The following is a description of a gene set: Human Gene Set: SMID_BREAST_CANCER_BASAL_DN We explored whether the five previously reported molecular subtypes in breast cancer show a preference for organ-specific relapse and searched for molecular pathways involved. The intrinsic gene list describing the subtypes was used to classify 344 primary breast tumors of lymph node-negative patients. Fisher exact tests were used to determine the association between a tumor subtype and a particular site of distant relapse in these patients who only received local treatment. Modulated genes and pathways were identified in the various groups using Significance Analysis of Microarrays and Global Testing. Bone relapse patients were most abundant in the luminal subtypes but were found less than expected in the basal subtype. The reverse was true for lung and brain relapse patients with the remark that absence of lung relapse was luminal A specific. Finally, a pleura relapse, although rare, was found almost exclusively in both luminal subtypes. Many differentially expressed genes were identified, of which several were in common in a subtype and the site to which the subtype preferentially relapsed. WNT signaling was up-regulated in the basal subtype and in brain-specific relapse, and down-modulated in the luminal B subtype and in bone-specific relapse. Focal adhesion was found up-regulated in the luminal A subtype but down-regulated in lung relapse. The five major molecular subtypes in breast cancer are evidently different with regard to their ability to metastasize to distant organ(s), and share biological features and pathways with their preferred distant metastatic site. Genes down-regulated in basal subtype of breast cancer samles. studied in species Homo sapiens from publication Smid M, Wang Y, Zhang Y, Sieuwerts AM, Yu J, Klijn JG, Foekens JA, Martens JW (PMID 18451135), and this is the list of marker genes: DZIP3, LINC01949, HPGD (15-hydroxyprostaglandin dehydrogenase), F13A1 (NCBI Gene Id 2162), ENTPD3, CPD, IKBKB, GP2, COG7, SOCS2 (suppressor of cytokine signaling 2), ANG, FBXL7, SPTLC2, NAIP, STARD3, BATF, FABP4, FGFR3, NF1, CEACAM6, INPP4B, ANO1, RBM47, MLPH, MAK, HEMK1, NTRK2, HGD, TIMP4, TNXA, ACADSB, CAMK2B, REEP5 (receptor accessory protein 5), SLC4A8, ABCC8, COMP, GNG13, ZNF552, BEX1, ANOS1, MAST4, GRIA2, AGR2, TSPAN13, SIX1 (SIX homeobox 1), AAMDC, ELAPOR1, CYP2B6 (NCBI Gene Id 82059), CACNA1H, EVL, SYT17, TFAP2B, ALCAM, MCF2L, LRRN3, KCTD3 (potassium channel tetramerization domain containing 3), ESR1, DGKD, TRAK1, STK39, IRX5, MSX2, ZNF43, PIDD1, LRBA, TOB1, HPX, ALG12, BCAS4, TTC9, CACNA2D2, ADCY9, TMEM143, SLC24A1, ABCA12, CACNG4, SORL1, HSDL2, OGN, C4A, SVEP1, TRIL, GTF2H2C, GJA1, OLFML3, FASN, SNHG14, NOVA1, FCMR, UBA7, TRAF5, TBC1D9, TRIM68, WWOX (WW domain containing oxidoreductase), PIERCE1, DEPTOR, ADIRF, BLVRB, MED24, FMO5, ATRNL1, TSPAN8, IL33, CYB5A, GGT1 (NCBI Gene Id 91347), CX3CR1, MED13L, RPS20P22, PDCD4, BLVRA, ZMYND8, RASSF1, NR4A2, CLSTN2, PDGFD, KCNE4, CXCL14, SMPD3, CFB, ITM2A, AOX1, HEBP1, XRCC4 (NCBI Gene Id 7518), SLC1A1, FAIM2, CYP2A6, SCNN1A, SLC39A6, SCCPDH, DNAAF1, GRP, SLC48A1, KRT8, KAZALD1, NAV3, AGL, ABCB1, ACACB (acetyl-CoA carboxylase beta), HGF, CA12, THBS4, BIK, ADIPOQ (adiponectin, C1Q and collagen domain containing), ATP8A2, LINC01503, TMEM101, REEP1, CEACAM5, CHAD, DCN, PAMR1, KRT18, CCNO (NCBI Gene Id 9998), C1QTNF3, MREG, TPSAB1, TUBA3E, BMI1, KIF13B, MAP3K12, NADSYN1 (NCBI Gene Id 55191), SLC9A1, CREB3L1, CDK12, RHBDL1, NPDC1, PLEKHF2, COL4A5, IFT122, TCEAL4, PNPLA2, SLC2A8, GPC1-AS1, RND1, EVA1B, SLC26A3, NHERF1, SNX1, PCSK6, LONP2, TRGC1, MYT1, ADCY1, ASPH (aspartate beta-hydroxylase), DHCR24, CILP, CACNA2D3, SERPINA5, ZBTB18, ATP1A2, ADRA2A, FLRT3, TFPI2, CHN2, CFAP69, CLBA1, EPOR (NCBI Gene Id 2057), C14orf132, ASPA, BRINP2, MFAP5, MAPT, SSTR2, PGR, IL6ST, ALOX15B, ARL3, RET, PSD3, PLXNB1, SPDEF, MAN1C1, C3orf52 (NCBI Gene Id 79669), PTPRT, CEP15, EPHX2, GSE1, SERHL, CYP4F8, NKAIN1, ABCA3, CAMK2N1, ENPP1, HMGCS2, CCDC170, PLIN1, PCK1, DNAI7, RAB17, PAX2, SYTL2 (NCBI Gene Id 84564), HSPB8, AR, GPRC5A, CRY2, SCD, DNALI1, DCAF10, ITGBL1, BCAS1, DUSP4, KCNAB1, GSTM3, CASD1, SCGN, PTPRN2, BMERB1, SLC1A4, RAPGEF3, RBP4, SLC16A6, FAM131B, PBX1, NAT2, ECM1, AKR7A3, RNASE4, OMD, ZNF446, EFHC1, HBA1, ITGA7 (NCBI Gene Id 81988), TTC12, PLAT, PLA1A, MACIR, LAMP5, SYBU, HOXB2, PLAAT4, CSAD, GLRB, SLIT3, GNMT, BBS4, RARA, LRRC17, CITED1, RTN1, KAT6B, VIPR1, AMDHD2, JMJD7-PLA2G4B, PRKACB, TTC39A, IQGAP2, IRS1, UGT2B15, LEP, CLCA2, PATJ, CYBRD1, NBEA, UGT2B11, RBM19, PTP4A2, RABEP1, SPAG16, KIF16B, SLC18A2, ACSM5, MYH11, HSPB1, CCN5, BRINP3, TCN1, SEPTIN8, UBL3, SCUBE2, PNPLA4 (patatin like phospholipase domain containing 4), CELSR1, BCL2, CAPN9, PLA2G10 (phospholipase A2 group X), SEC14L2, MZF1, LRIG1, LIAS, SPARCL1, CDS1, CLDN5, BTG2, SEMA3C, ICA1, C2CD2L, SPATA7 (NCBI Gene Id 55812, spermatogenesis associated 7), HIGD1B, ZNF329, NUCB2 (nucleobindin 2), PDZK1, RHOH, CCNG2, HCFC1R1, FOSB, NEBL, DDO, LIPE, TJP3, CFAP45 (NCBI Gene Id 25790), ELOVL2, GJA4, EFCAB2, NPY1R, TSPAN1, GSTT2, SELENOP (selenoprotein P), HOXB6, MAGED2, CXXC4, CST5, INPP5J, SNED1, GNA14, LDLRAD4, CACNA1D, ERBB4, CATSPERB, PPDPF, CRISP3, COL4A6, TRIM3, MS4A2, EEF1A2, STS, SLC38A1, ABCA8, MDM1, ERBB3, PGGHG, PPIP5K1, NAT1, NCOA3, ACSL3, ANXA9, TK2, CPB1, PGAP3, WWP1, TSKU, FUT8, RAPGEFL1, FAAH, ARMT1, TPPP3, FCER1A, ALG8, KCND3, EMCN, CLEC3B, HSPA2, STC2, APPBP2, DLG5, ZNF385D, SCGB1D2, DIO1, CFD, PRLR, DNAJC1, TNNT1, IFT140, CAMP, TM7SF2, HNMT, UCP2, ALDH3B2, PCDHA9, CERS6, ATP8A1, STK32B, POLM, MYB, MTARC1, RGS11, GALNT6, ZNF652, G6PC3 (NCBI Gene Id 92579), NEDD4L, ARHGAP32, PLCL1, AMIGO2, ACKR3, PCLO, RETREG1 (reticulophagy regulator 1), SSH3, ISYNA1, CRIP2, MSL1, CD36, SLC7A8, DNAAF11, FRY, FBP1, BMPR1B, FAXDC2, PEX11A, SIDT1, RNF41, TNIK, IL20RA, MKNK2, RAI2, FBLN1, SIGIRR, KRT19, EPS8L1, POLD4, IVD, PCBP2, MUC6, ARHGAP35 (NCBI Gene Id 79266), TP53TG1, TMEM265, PAN2, IGF1, ACKR1, DENND1B, LGALS8, KDM4B, GPD1, GATA3, QDPR (NCBI Gene Id 5860), CHST1, KMO, PLAAT2, LIN7A, NME3, BAIAP3, LMF1, RAB27B, ZNF91, ESRRG, SIGLEC15, GASK1B, SFRP4, HEATR6, FGG, ENSG00000301761, APBB2, GFRA1, MYO6, SEMA3B, ELF1, SERPINI1, SPRR3, SH3BGRL, NELL2 (neural EGFL like 2), MUC1, SORD, SRI, FAM174B, CST3, KIF5C, DHRS2, ABAT, DNMBP, ST6GALNAC2, ATP7B, TFF1, ACACA, SLC2A10, HDAC11, DPT, CXCL12, CERS4, GALNT7, MSMB, SLC6A4, VAV3, BCAM (basal cell adhesion molecule (Lutheran blood group)), CCND1, BMP4, RHOB, CHRD, FGB, NRIP1, UGCG, RAB38, ZNF587, AAGAB, ASCL1, ADH1B, DNAJC12, SNCG, NQO1, ZCCHC24, CYP2B7P, NFIA, XIST, ALDH4A1, CNTNAP2, IGFBP4, SELENBP1, GSTZ1, ZNF839, CCL14, SREBF1 (sterol regulatory element binding transcription factor 1), CYB561, APOD, MFAP4, MAP9, DCLK1, FDXR, SLC44A4, NR2F1, UNC119, KIAA0319L, ABCC6, DCXR, NPIPB3, ASPN, RAB26, PNMT, CROT, SCGB2A2, GDF15, SLC27A2, GATA2, SLC22A18, ZSCAN18, UGDH, GPD1L, CANT1, METRN, PVALB, MMP17, MISP, ASAH1, GATB, SLC19A2, YIPF6, AREG, GALNT10, COL14A1, TKFC, SLC35E3, SUPT6H, TBX3, RALGPS1, WIPF2, PCSK5, CACNG1 (NCBI Gene Id 786), GPC3, FAM83E, NUDT4 (nudix hydrolase 4), SGSH, SNPH (syntaphilin), SLC4A7, KCNMA1, MIPEP, TAT, PIEZO2, ERBB2, HPN, PRSS23, PIP, MAN1A1, AZGP1, RGS5, DZANK1, ZBTB16, CYP21A2, SPHK2, PPP1R3C, CYP4B1, CCDC106, SERHL2, ACOX2, ALB, CRAT, ADGRB2, GOLGA2P5, MRPS30, SYT1, MATN3, TRIM36, AFP, FAM234B, SEMA3G, PDS5B, COQ7, ALDH1A1, PTK6, SERPINA6, MAOA, REPS2, TREM2, TBC1D30, CPA3, DACH1, PTGER3, RMND1, CSF3R, LRRC31, C1orf21, KIAA0040, ABLIM3, ELOVL5, DUSP6, KCNJ3, STAU2, TNFSF10, TESMIN, ITPR1, RDH16, TBC1D19, GPRC5C, DGLUCY, GREB1L, GUSBP3, MCCC2 (NCBI Gene Id 64087), SLC49A3, MEGF9, CNR1, PLAAT3, COQ4, CLGN, TOM1L1, ATP2A3, RALGPS2, EPHA3, MON2, F7, CRIP1, TOX3, UCN, TMC5, GUSBP14, IGF1R, ABCG1, AK5, GREB1, N4BP2L2, DLG3, ERLIN2, GAMT, RAB11FIP1, FAM110B, MTUS1 (microtubule associated scaffold protein 1), B9D1, CPE, NME5, TFF3, ASTN2, PTHLH, SIL1, ABCC3, CBFA2T3, EXOC7, MEOX2, SGK3, DUSP5, AGTR1, EGR3, AHNAK, CYP26A1, FAH, HHEX, CYP2E1, TMEM30B, AQR (NCBI Gene Id 9716), PBLD